The following is a description of a gene set: species: Homo sapiens Human Gene Set: ZNF157_TARGET_GENES from publication Yevshin I, Sharipov R, Kolmykov S, Kondrakhin Y, Kolpakov F (PMID 30445619) Genes containing one or more binding sites for (ZNF157) in their promoter regions (TSS -1000,+100 bp) as identified by GTRD version 20.06 ChIP-seq harmonization., and this is the list of marker genes: ZNF585B, CREB5, LINC00431, SLC66A2, CCDC171 (NCBI Gene Id 203238), NFASC (neurofascin), MAF1P1 (NCBI Gene Id 391578), VANGL1, STAT6, THA1P, CEROX1, SLC29A4, RPS15A, ARID1B, NOD2, MIR4646, CC2D1A, COX5BP2, KIDINS220, CYCSP26, NXNP1, GABBR1, ATP1A3 (NCBI Gene Id 95633), KLHDC9, ZNF404, SPON2, ZNF691, LMF1, TBXA2R, SNORA24B, CACNA1C, FCAR, RASL11A, FBXL2, NOL6, LBX1-AS1, RN7SL810P, SELENOP, MIR6792, SMC4 (NCBI Gene Id 10593), GBA1, TOP6BL, TMEM248 (NCBI Gene Id 55069), CDC42EP4, CXXC1, PRSS8, PPIAP59, FCHSD2, RIMKLB, CWC25, LMO4, CPAMD8, CSNK1G2, PKD1, ARHGEF11, LINC02976, B4GALT7, ARIH2, DOK4, HPRT1P3, SCN1B (NCBI Gene Id 6324), CEP170B, MIR6807, ZNF555, SLC25A23, VPS51, PITPNM2, GINS1, SAXO3, MIOS, ENSG00000267058, CCN1, TOM1, SOX8, ILVBL-AS1, BEND7, COL6A1, FZR1, CACNA1A, MSRB1, EVPL, RPL31P46, ZNF45-AS1, CNIH3, B3GNT6